Given this list of marker genes Dhfr, Ctsb, Ppib, Aldoa, Timp2, Fn1, Rpl10a, Tpi1, Eno1, Cdh1, Akr1a1, Clu, Mcpt8, Lgals3bp, Sdc4, Ldha, Gprasp1, Cant1, Got2, Mdh1, Ywhaz, Ctsh, Psmb5, Cytip, App, Pgk1 (NCBI Gene Id 214853), Agrn, Cdc25b (NCBI Gene Id 99033), Tpt1, Fdps, Ctsa, Cx3cl1, C2, Psma4, Taldo1, Cst3, Igfbp4, Sdc1, Chaf1a, Gstm1, Kctd7, Creg1, Psma7, Msln, Cdh17, Enpp2 (ectonucleotide pyrophosphatase/phosphodiesterase 2), Gsta4, Pebp1, Psmb6, Actb, Bgn, Rack1, Phactr4, Npc2, Cfb, Hsp90ab1, Cp, Vcam1, Col18a1, Dut, Got1, Ctsl, Ran, Cd81, Anxa2, Clstn1, Ctsd, Psmb7, Prdx1, Psma6, Tut1, Ralyl, Prl2c3, Psat1, Prss1, Gsto1, Mdh2, Itih2, Pgam2, here is a description of the gene set: Mouse Gene Set: ZHONG_SECRETOME_OF_LUNG_CANCER_AND_MACROPHAGE from publication Zhong L, Roybal J, Chaerkady R, Zhang W, Choi K, Alvarez CA, Tran H, Creighton CJ, Yan S, Strieter RM, Pandey A, Kurie JM (PMID 18757440) Non-small cell lung cancer (NSCLC) cells with somatic mutations in K-ras recruit to the tumor a variety of cell types (hereafter collectively termed stromal cells) that can promote or inhibit tumorigenesis by mechanisms that have not been fully elucidated. Here, we postulated that stromal cells in the tumor microenvironment alter the tumor cell secretome, including those proteins required for tumor growth and dissemination, and we developed an in vitro model to test this hypothesis. Coculturing a murine K-ras mutant lung adenocarcinoma cell line (LKR-13) with a murine lung stromal cell (macrophage, endothelial cell, or fibroblast) enhanced stromal cell migration, induced endothelial tube formation, increased LKR-13 cell proliferation, and regulated the secretion of proteins involved in angiogenesis, inflammation, cell proliferation, and epithelial-to-mesenchymal transition. Among these proteins, CXCL1 has been reported to promote NSCLC development, whereas interleukin-18 (IL-18) has an undefined role. Genetic and pharmacologic strategies to inhibit CXCL1 and IL-18 revealed that stromal cell migration, LKR-13 cell proliferation, and LKR-13 cell tumorigenicity required one or both of these proteins. We conclude that stromal cells enhanced LKR-13 cell tumorigenicity partly through their effects on the secretome of LKR-13 cells. Strategies to inhibit tumor/stromal cell interactions may be useful as therapeutic approaches in NSCLC patients. Proteins secreted in co-culture of LKR-13 tumor cells (non-small cell lung cancer, NSCLC) and MHS stroma cells (macrophages). studied in species Mus musculus